The following is a description of a gene set: from publication Hale JS, Youngblood B, Latner DR, Mohammed AU, Ye L, Akondy RS, Wu T, Iyer SS, Ahmed R (PMID 23583644) Genes down-regulated in CD4 SMARTA cells: naïve versus during acute infection of LCMV. studied in species Homo sapiens Human Gene Set: GSE43863_NAIVE_VS_TH1_EFF_CD4_TCELL_D6_LCMV_DN CD4 T follicular helper (Tfh) cells provide the required signals to B cells for germinal center reactions that are necessary for longlived antibody responses. However, it remains unclear whether there are CD4+ memory T cells committed to the Tfh lineage after antigen clearance. Using adoptive transfer of antigen-specific memory CD4+ subpopulations (based on CXCR5 and Ly6c expression)in the LCMV infection model, we found that there are distinct memory CD4+ T cell populations with commitment to the Tfh and Th1 lineages. Our conclusions are based on gene expression profiles, epigenetic studies and phenotypic and functional analysis. The gene expression profiles of virus-specific CD4 T cell subets at effector and memory stages is presented here., and this is the list of marker genes: PPP1R27, GNAT2, MAF, GALNT18, ESRRB, SV2B (NCBI Gene Id 9899), INPP4B, UCP2, SPTLC3, MX1, OR10C1, TREML5P, SPATA16, FAM219B, MAP2, CASP8, ZNF502, LINC00511, PAMR1, PTGER1, CGA, RTP4, CDC14B (cell division cycle 14B), FGFBP1, FCGR2C, TP53AIP1, CPA2, LCNL1, ASB6, AMELY, C11orf54, SIX2, LINC01541, MT1M, CHRNA6, ARK2C, FZD5, PRR14, TRIB1, PGS1 (phosphatidylglycerophosphate synthase 1), SLC7A9 (solute carrier family 7 member 9), TTTY14, MKS1, MT1H, ODAM, LITAF, MFAP4, IDO1, KLRD1, GCH1, PER2, KRBA2, NAALADL2, FLRT1, RET, C1QTNF6, LUZP4, NHLH2, RASGRP3, SOX21, UBE2L6, SYNPO2L, SCGB1D1, TNF, GRK7, CARS1, CA5B (NCBI Gene Id 11238), NDST3, BOLL, NTN5, CD274, CFHR4, CECR2, LRP5, TNFSF11, CCDC172, SP110, GCM1, IFNLR1, SLC44A4, SLC25A48, DPPA5P4, ABCA5, CNGA1, MT1F, FCF1, CEBPB, OR2J3, OR9A1P, RNF213, SLC28A3, LINC02175, FAR2P1, ZNF436-AS1, TRAFD1, DNAH17-AS1, BCL10-AS1, C9orf57, CHAD (chondroadherin), PPP1R36, CYP11A1, SOX3, NLRP13, CYLD, NOD2 (nucleotide binding oligomerization domain containing 2), MRGPRX3, TRIM46, PSME2, EPSTI1, SELE, CCL11, SCRT1, CCL5, MZF1-AS1, H3-4, TTC4, CSH1, ASB4, GBP5, CYTL1, LINC00919, TRPC2, ENHO, SPART-AS1, BIK (NCBI Gene Id 638), DISC1, RAB36, SPAG4, KIF24, CST13P, RPL23A, PAX1, H2BC17, RIGI, ISG20, ZNF687, PRODH, SLC10A2, MT2A, SPHKAP, ART3, STPG3, POLR2H, POM121L12, BMAL1, C2CD4A (NCBI Gene Id 145741), DYRK4, MC3R, FGD2, CCDC174, PPM1L, DRAXIN, NPBWR2, CRYBG1, TIMP4, PIEZO2, WDR24, BEX1, LINC00543, DEFB118, CASP10, LINC01618, RND1, LINC02825, SAMD15, TSNAXIP1, LINC00641, SLC25A28, PIN4, NCDN, ZNF419, DPH7, EPHA4, NTSR2, DCT, GUCY2C, ATP6V0E2-AS1, CD5L, TWNK, TRIM72, AA06, TAP2, MT1G, CXCL8, OPA3, GIMAP5, ACTR3BP2, LINC00683